Given this list of marker genes BRAF, RIT2, NGF, RIT1, NTRK1, here is a description of the gene set: Reactome Pathway: Signalling to p38 via RIT and RIN RIT and RIN are two small guanine nucleotide binding proteins that share more than 50% sequence identity with RAS, including highly conserved core effector domains. Unlike RAS, the C termini of RIT and RIN lack a typical prenylation motif (CAAX, XXCC, or CXC) required for the association of RAS proteins with the plasma membrane. RIT is expressed in all tissues, whereas RIN is neuron-specific. They have similar signalling properties and are activated by NGF through unknown exchange factors. They signal to ERKs and p38 MAP kinase. They mainly lead to p38 activation via the BRAF-MEK kinase cascade. species: Homo sapiens part of: Signalling to ERKs